Given this list of marker genes CXCL8, DUSP1, SOX9, MAD2L1BP, HBEGF, PMAIP1, IER3, H2AC18, PHLDA2, RND3, ATF3, MYD88, TAX1BP3, EIF2S1, PTGS2, H2BC21, H2AX, CYCS, BRD2, HSPA1B, ATP6V0D1 (ATPase H+ transporting V0 subunit d1), IL1B, here is a description of the gene set: Human Gene Set: SESTO_RESPONSE_TO_UV_C3 Cluster 3: genes changed in primary keratinocytes by UVB irradiation. from publication Sesto A, Navarro M, Burslem F, Jorcano JL (PMID 11867738) studied in species Homo sapiens UV radiation is the most important environmental skin aggressor, causing cancer and other problems. This paper reports the use of oligonucleotide microarray technology to determine changes in gene expression in human keratinocytes after UVB treatment. Examination of the effects of different doses at different times after irradiation gave a global picture of the keratinocyte response to this type of insult. Five hundred thirty-nine regulated transcripts were found and organized into nine different clusters depending on behavior patterns. Classification of these genes into 23 functional categories revealed that several biological processes are globally affected by UVB. In addition to confirming a majority up-regulation of the transcripts related to the UV-specific inflammatory and stress responses, significant increases were seen in the expression of genes involved in basal transcription, splicing, and translation as well as in the proteasome-mediated degradation category. On the other hand, those transcripts belonging to the metabolism and adhesion categories were strongly downregulated. These results demonstrate the complexity of the transcriptional profile of the UVB response, describe several cellular processes previously not known to be affected by UV irradiation, and serve as a basis for the global characterization of UV-regulated genes and pathways.